The following is a description of a gene set: species: Homo sapiens Human Gene Set: HP_AORTIC_VALVE_STENOSIS The presence of a stenosis (narrowing) of the aortic valve. Aortic valve stenosis, and this is the list of marker genes: DPH2, NPHP3, IDUA, ANKS6, LTBP2, EHMT1, NKX2-5, RIGI, FGFR1, SLC2A10, NOTCH1, CLIC2, TRAF7, ABCC6, ACTB, LMNA, ARHGAP31, DYRK1A, B4GALT7, NOTCH2, ARSK, GNPTG, WT1, RMRP, CHST3, ADAMTSL2, FLI1, VWF, CBL, EP300, TWIST1, SNIP1, ZMPSTE24, TAB2, SMAD6, IFIH1, KRAS, TAF2, BCOR, EBP, ODAD1, NR2F2, ADAMTS10, ADAMTS17, ABCG8, CCDC22, SMAD4, GBA1, CREBBP, GLB1, WASHC5, ROBO4, KDM6A, ABCG5, ZEB2, SCN1B, TTR, HAAO (NCBI Gene Id 23498), FBN1, KMT2D, DPYSL5, ENPP1, VPS35L, GATA5, DPH1 (NCBI Gene Id 1801), NEK8, HGD, AMER1, FOXF1